The following is a description of a gene set: PTEN is a tumor suppressor that dephosphorylates the lipid messenger phosphatidylinositol triphosphate. studied in species Homo sapiens Human Gene Set: SA_PTEN_PATHWAY, and this is the list of marker genes: BPNT1, RBL2, AKT3, SHC1 (SHC adaptor protein 1), PIK3CA, AKT2, ILK, PTK2B, SOS1, AKT1, MAPK1, PTEN, MAPK3, GRB2, IPCEF1, PDPK1, PIK3CD